Given this list of marker genes Dgcr8, Ripk1, Bmp4, Tgfb1, Trub1, here is a description of the gene set: Mouse Gene Set: GOBP_POSITIVE_REGULATION_OF_MIRNA_PROCESSING studied in species Mus musculus Any process that activates or increases the frequency, rate or extent of microRNA processing.